The following is a description of a gene set: Mouse Gene Set: MEISSNER_BRAIN_HCP_WITH_H3K27ME3 DNA methylation is essential for normal development and has been implicated in many pathologies including cancer. Our knowledge about the genome-wide distribution of DNA methylation, how it changes during cellular differentiation and how it relates to histone methylation and other chromatin modifications in mammals remains limited. Here we report the generation and analysis of genome-scale DNA methylation profiles at nucleotide resolution in mammalian cells. Using high-throughput reduced representation bisulphite sequencing and single-molecule-based sequencing, we generated DNA methylation maps covering most CpG islands, and a representative sampling of conserved non-coding elements, transposons and other genomic features, for mouse embryonic stem cells, embryonic-stem-cell-derived and primary neural cells, and eight other primary tissues. Several key findings emerge from the data. First, DNA methylation patterns are better correlated with histone methylation patterns than with the underlying genome sequence context. Second, methylation of CpGs are dynamic epigenetic marks that undergo extensive changes during cellular differentiation, particularly in regulatory regions outside of core promoters. Third, analysis of embryonic-stem-cell-derived and primary cells reveals that 'weak' CpG islands associated with a specific set of developmentally regulated genes undergo aberrant hypermethylation during extended proliferation in vitro, in a pattern reminiscent of that reported in some primary tumours. More generally, the results establish reduced representation bisulphite sequencing as a powerful technology for epigenetic profiling of cell populations relevant to developmental biology, cancer and regenerative medicine. studied in species Mus musculus from publication Meissner A, Mikkelsen TS, Gu H, Wernig M, Hanna J, Sivachenko A, Zhang X, Bernstein BE, Nusbaum C, Jaffe DB, Gnirke A, Jaenisch R, Lander ES (PMID 18600261) Genes with high-CpG-density promoters (HCP) bearing the H3K27 tri-methylation (H3K27me3) mark in brain., and this is the list of marker genes: Thbs4, Irs3, Npy, Hoxb4, Tnxb, Krt19, Bcl3, Tdrd6, Tlx3, Mixl1, Pyy, Npas1, Lbx2, Cdcp1, Mafa, Tbx21, Prdm14, Gbx1, Grb10, Spag16, Barx1, Wnt3a, Fgfr4, Fgf8, Pax2, Slc44a3, Foxe3, Prss50, Igfbpl1, Hmx3, Wt1, Pdx1, Aqp5, Dhh, Foxd4, Ntf5, Bhlhe23, Irx4, Calb2, Amn, Six1, Dlk1, Col8a2, Znrf4, Hoxc8, Sim1, Gata4, Gata3, Tfap2c, Hoxd11, Ecel1, Tfap2e (transcription factor AP-2, epsilon), Sall4, Fgf17, Fgf4, Pax7, Hoxb7, B4galnt2, Esx1, Epcam, Ppm1n, Sfrp5, Krt18, Krt87, Gfra3, Igf2bp3, Prdm6, Lgr6, Slc18a2, Large2, Prr5, Cdx1, Hoxd1, Slc47a1, Bmp8b, Hoxa13, Slc30a2, Hnf1b, Hmx2, Uncx, Gja3 (NCBI Gene Id 14611), Igf2 (NCBI Gene Id 16002), Ffar4 (free fatty acid receptor 4), Lmx1a, Hoxd9, T, Pax1, Nkx6-1, Tlx2, Hmx1, Pitx2, Fam89a, Irx2, Alx1, Wdr86, Foxc2, Aebp1, Spag6, Dmbx1, Plbd1, Dlx4, Otp, Prrx2, Igf2bp1, Trpv4, Glp1r, Phox2a, Hoxb6, Dmc1 (DNA meiotic recombinase 1), Hoxa11, Plekhg6, Tdh, Mfsd6l, Irx6, Cldn3 (claudin 3), Lhx5, Fev, Slc47a2, Tpm2, Hoxc11 (homeobox C11), Lhx1, Nkx2-5, Gbx2, Alx4, Bnc1, Ikzf3, Rem1 (rad and gem related GTP binding protein 1), Hand1, Foxd3, Erfe, Dmgdh, Hoxd12 (homeobox D12), Gm5878, Hoxc12, Tmem54, Mnx1, Trp73, Foxd2, Marcksl1, Slc18a3, Hoxc5, Onecut3, Pou4f3, Hoxa4, Alx3, Foxb1, Gnas, Vsx2 (visual system homeobox 2), Gfi1, Hoxc13, Pitx1, Prdm13, Notch3, Ptf1a (pancreas specific transcription factor, 1a), Rspo4, Celsr1, Gpr50 (NCBI Gene Id 14765), Rbmxl2, Slc5a5, Ltbp2, Mesp1, Cldn4, Barhl2, Kcnk15, Hoxc4, Neurog3, Nags, Wnt10b, Lmx1b (NCBI Gene Id 16917), Hmga2, Kdf1, Hoxb5, Espn, Foxn4, Helt, Ovol1, Kcp, Foxa2, Scarf2, Col13a1, Rax, Prom2, Cyp4f39, Atp2a3, Tcfl5, Lbx1, B3gnt3, Gsc, Dmrta1, Irf6 (NCBI Gene Id 98477), Crlf1, Hes2, Chat, Cyp26a1, Hoxb9, Drd4, Gsx2, Pou4f2 (POU domain, class 4, transcription factor 2), Tlx1, Draxin, Gal, Sim2, Grin3b, Dmrt1, Mmp2, Gata5, Cldn7, Tbx1, Spint1, Cdx2, Fgf20, Nkx2-1, Lhx8, Foxl1, Pkp1, Dbx1, Aldh1a3, Loxl1, Them7, Pcsk9 (proprotein convertase subtilisin/kexin type 9), Crb3, Evx1, Barhl1 (BarH like homeobox 1), Utf1, Six2, Nkx3-2 (NCBI Gene Id 12020), Hes3, Wnt7b, Cyp24a1, Otop1, Foxb2, Hoxa5, Cblc, Hoxd10, Gdf7, Il12rb2, Insrr, Tnfaip2, Olig3, Chmp4c, Neurog1, Dio3, Rhcg, Insm2, Wnt2b, Krt7, Hoxd8, Fgf3, Hand2, Slc6a2, Gnmt, Kcne5, Drgx, Chrna3, Vax2, Ankrd53, Wnt3, Ncmap, Lhx3, Foxe1, Hoxa10, Adamts14, Calcr, Dmrt3, Tmem171, Nkx2-4, Tmem30b, Myod1, Scnn1b, Hoxd13, Six6, Dlx3, Pou2f3, Emilin3